Given this list of marker genes SLC4A5, TTYH3, NMUR2 (neuromedin U receptor 2), C8orf44-SGK3, ABCC5, GABRA5, FXYD1, GABRR1, SLC13A4, SLC22A1, GABRA3, GABRG2, SLC22A11, SLC26A6, SLC26A4, SGK1, CLIC2, GABRG1, SLC13A1, CLCA4, SLC20A2, CLCN1, CLCNKA, SLC4A7, STX7, SLC4A3 (NCBI Gene Id 7858), VTI1B, CLCNKB, MFSD8, SLC17A7, GABRB2, ANO1, SLC17A8, SLC12A7, SLC6A12, ABCC2, SLC25A27, GABRR2, SLC4A4, SLC25A10 (NCBI Gene Id 1468), SLC25A30 (NCBI Gene Id 253512), SLC22A8, SLC25A25 (NCBI Gene Id 114789), SLC17A2, PACC1, ANO4, CLIC4, SLC6A3, CFTR, ANO6, ANO7, SLC22A6, ANO5, CLCN7, SLC12A8 (NCBI Gene Id 84561), MFSD5, GLRA3, ADAMTS8, NHERF1, ABCC6, SLC6A11 (NCBI Gene Id 6538), SLC17A4, SLC1A1, CLIC6, SLC12A6, SLC4A9, SLC26A8, TTYH2, SLC26A2, SLC17A1, ANO8, GABRA4, CLCN4, CLDN17, SLC6A2, GABRG3 (gamma-aminobutyric acid type A receptor subunit gamma3), SLC25A14 (NCBI Gene Id 9016), SLC4A8, SLC26A7, ABCC1, SLC6A6, SLC12A1, CLCN3, SLC1A7, APOL1, CLIC3, ABCC3, SLC26A9 (solute carrier family 26 member 9), ANO10, SLC6A13, CHRNA7, SLC26A5 (solute carrier family 26 member 5), SLC37A1, SLC26A11, SLC17A3, SLC25A3, CLIC5, SLC37A2, SLC6A4, SLC17A6, SLC20A1, SLC4A11, SLC26A1, SLC6A8, ANO9, SLC37A4, SLC12A3, SLC34A3, ABCC10, GABRA1, CLIC1, SLC37A3, GABRA6, ANKH, SLC5A8, SLC4A10, CLCN6, GABRQ (NCBI Gene Id 55879), BEST4, GLRA2, FXYD3, CLCN5, SLC26A10P, ABCC11, CLCA1, GLRB, CLDN4, GABRE (gamma-aminobutyric acid type A receptor subunit epsilon), GET3, SLC12A2, AQP6, SLC26A3 (NCBI Gene Id 1811), SLC12A4, BSND, ABCC9, STX1A, SLC4A1, CLCN2, XPR1, SLC4A2, TTYH1, SLC12A9, SLC18A1, GABRB3, SGK3, STX8, GABRD, BEST2 (bestrophin 2), SLC34A2, SLC1A4, GABRB1, SLC25A23, SLC5A6, GABRA2, BEST3, GABRR3, SLC5A5, CLCC1, OCA2, TMC4, GABRP, SLC25A24, SLC34A1, SLC6A18, SLC12A5, ANO3, CLCA2, VAMP8, BEST1, GLRA1, SLC18A2, UCP2, ABCC4, SLC6A1, ANO2, here is a description of the gene set: Human Gene Set: GOMF_INORGANIC_ANION_TRANSMEMBRANE_TRANSPORTER_ACTIVITY Enables the transfer of inorganic anions from one side of a membrane to the other. Inorganic anions are atoms or small molecules with a negative charge which do not contain carbon in covalent linkage. studied in species Homo sapiens